The following is a description of a gene set: Increased body mass index studied in species Homo sapiens Abnormally increased weight-to-height squared ratio, calculated by dividing the individual's weight in kilograms by the square of the individual's height in meters and used as an indicator of overweight compared to averages. Human Gene Set: HP_INCREASED_BODY_MASS_INDEX, and this is the list of marker genes: THOC2, CORIN, FLT1, THRA, STOX1